Given this list of marker genes NPC1L1, CAV1, LIPG, APOF, MIR33A, LAMTOR1, SPG11, OSBPL3, PPARG, ADIPOQ, CES1, PTCH1, VPS53, APOA1, MIR27A, MTTP, SLC22A24, LDLRAP1, STARD4 (StAR related lipid transfer domain containing 4), OSBPL5, APOC1, MAPK3, MIR33B, MIR301B, OSBPL1A, MIR144, ARV1, FURIN, TMEM97, COMMD1, VPS52, SIRT1 (sirtuin 1), RXRA, OSBP, MIR19B1, MIR93, MIR302A, PIP4K2A, TSPO2, GPS2, APOA2, GRAMD1A, ABCA8, LRP1, MIR758, MIR27B, SHH, MIR9-1, NUS1, LCAT, MSR1 (NCBI Gene Id 4481), OSBPL9, GRAMD1B, NFKB1, TPCN2, STAR, MIR130B, CLU, APOC3, ANXA2P2, GRAMD1C, SOAT1, TREM2, ANXA2 (annexin A2), VAPA, ABCG5, OSBPL7, MIR145, SERAC1, PCSK9, CFTR (CF transmembrane conductance regulator), NFKBIA, ABCB4, SYT7, ABCG1 (ATP binding cassette subfamily G member 1), MIR128-1, COMT, VPS54, PON1, MIR185, TSPO, VPS4B, SREBF2, APOE, ABCA1, NAXE (NAD(P)HX epimerase), VAPB, MIR206, ABCA13, ABCG8, NPC1, OSBPL2, LIPC, EEPD1, EGF, VPS51, SOAT2, MIR17, ABCA12, STARD5, LDLR, SEC24A, APOB, TTC39B, NR1H3, MIR148A, OSBPL6, ARL8B, SCP2, LIPA, NPC2, ZDHHC8, APOC2, ABCA3, MIR613, CD36, STARD3, PLA2G10, SCARB1, ABCA7 (ATP binding cassette subfamily A member 7), MIR26A1, APOA4 (apolipoprotein A4), STARD3NL, CETP (cholesteryl ester transfer protein), ABCG4, YJEFN3, VPS4A, TSKU, APOM, RELCH, STX12, APOA5, NR1H2, ABCA5, PLTP (phospholipid transfer protein), ABCA2, here is a description of the gene set: species: Homo sapiens The directed movement of sterols into, out of or within a cell, or between cells, by means of some agent such as a transporter or pore. Sterols are steroids with one or more hydroxyl groups and a hydrocarbon side-chain in the molecule. Human Gene Set: GOBP_STEROL_TRANSPORT